Given this list of marker genes PACS1, USP7, RNF135, DLAT, RAI1, KANSL1, NONO, EBF3, GRIN2A, SPART, PURA, STUB1, FOXP1, PTEN, GALK1, DMPK, MAPT, KDM6B, FOXP2, SRPX2, POU4F1, SLC25A15, GALT, PRKAR1B, SH2B1, TRAPPC11, MED13, SRCAP, CHD3, CHD1, FRRS1L (ferric chelate reductase 1 like), SLC6A8, here is a description of the gene set: Human Gene Set: HP_SPEECH_APRAXIA species: Homo sapiens A type of apraxia that is characterized by difficulty or inability to execute speech movements because of problems with coordination and motor problems, leading to incorrect articulation. An increase of errors with increasing word and phrase length may occur. Speech apraxia